The following is a description of a gene set: Human Gene Set: GOCC_I_BAND A region of a sarcomere that appears as a light band on each side of the Z disc, comprising a region of the sarcomere where thin (actin) filaments are not overlapped by thick (myosin) filaments; contains actin, troponin, and tropomyosin; each sarcomere includes half of an I band at each end. studied in species Homo sapiens, and this is the list of marker genes: KCNE1, PPP3CB, JPH1, AKAP4, SYNPO2, DNAJB6, LDB3 (NCBI Gene Id 1219), PRKD1, CTNNB1, FKBP1B, PDLIM3, ANK2, SMTNL1, ANKRD1, FLNB, MYH7, TRIM54, REM1, ACTN2, MYL9, FBXO22, OBSCN, PARVA (NCBI Gene Id 80050), CSRP1, MTM1, TUFT1, PDLIM2, PALLD, S100A1, SMN1, ANKRD23, C10orf71, NOS1AP, PPP1R12A, KCNN3, MYO18B, BMP10, PLEC, FERMT2, NEXN (nexilin F-actin binding protein), ALDOA, ATP2B4, FBP2, KRT19, FBXO32, DNAJB4, SYNPO2L, CACNA1C, FHOD3, FRG1, PDE4B, FLNC, MYPN, PAK1, MYL3, PRICKLE4, FHL2, BAG3, PDLIM7, HSPB1, JUP, SYNPO, PPP3CA, IGFN1, ANK1, DST, NEB, CACNA1S, GGPS1, CASQ2, PDLIM5, NRAP, SLC4A1, MYOT, KAT2B, SCN5A, PDLIM4, DMD, SLMAP, SYNC, RYR1, JPH2, TRIM63, FHL3 (NCBI Gene Id 2275), CACNA1D, CAB39, FKBP1A, CSRP2, SLC8A1, FBXL22, SCN1A (NCBI Gene Id 6323), UNC45B, HOMER1, PPP1R12B, MYOZ2, MYL12B, NOS1, ANKRD2, KCNN1, CSRP3, CAV3, MYOZ1, SMN2, ITGB1BP2, NEBL, SLC2A1, SORBS2, PARVB, KRT8, MYZAP (myocardial zonula adherens protein), KCNN2, ATP2A1, ACTN4, TCAP, CRYAB, KCNA5, DES, FHL5, POLR2M, OBSL1, SYNE2, GLRX3, MYOZ3, RYR3, MYH6, CFL2, KY, SRI, CAVIN4, SCN3B, FLNA, ASB2, SCN8A, PPP2R5A, PDLIM1, ACTN1 (actinin alpha 1), XIRP2 (xin actin binding repeat containing 2), KLHL40, ACTN3, RTN2, PGM5, TTN, HRC, RYR2, CAPN3, ACTC1, ANK3, BIN1, STUB1, CASQ1